The following is a description of a gene set: from publication Fuller CL, Brittingham KC, Porter MW, Hepburn MJ, Petitt PL, Pittman PR, Bavari S (PMID 17349694) Genes up-regulated in peripheral blood mononuclear cell (18 to 336)h vs 0h in adults (22-54) after exposure to F. tularensis vaccine LVS, time point 18 to 336H. Comment: Pattern 3, sustained-up. These approx 9 of genes in pattern linked to immune function. The live vaccine strain (LVS) of Francisella tularensis is the only vaccine against tularemia available for humans, yet its mechanism of protection remains unclear. We probed human immunological responses to LVS vaccination with transcriptome analysis using PBMC samples from volunteers at time points pre- and post-vaccination. Gene modulation was highly uniform across all time points, implying commonality of vaccine responses. Principal components analysis revealed three highly distinct principal groupings: pre-vaccination (-144 h), early (+18 and +48 h), and late post-vaccination (+192 and +336 h). The most significant changes in gene expression occurred at early post-vaccination time points (<=48h), specifically in the induction of pro-inflammatory and innate immunity-related genes. Evidence supporting modulation of innate effector function, specifically antigen processing and presentation by dendritic cells, was especially apparent. Our data indicate that the LVS strain of F. tularensis invokes a strong early response upon vaccination. This pattern of gene regulation may provide insightful information regarding both vaccine efficacy and immunopathogenesis that may provide insight into infection with virulent strains of F. tularensis. Additionally, we obtained valuable information that should prove useful in evaluation of vaccine lots as well as efficacy testing of new anti-F. tularensis vaccines. Human Gene Set: FULLER_PBMC_F_TULARENSIS_VACCINE_LVS_AGE_22_54YO_18HR_TO_336HR_SUSTAINED_UP studied in species Homo sapiens, and this is the list of marker genes: MAPKAPK3, ARRB1, VAMP8, M6PR, ATL3, SPN, CD300A, LRP1, TXNIP